The following is a description of a gene set: Human Gene Set: GAVISH_3CA_METAPROGRAM_ENDOTHELIAL_ENDO_5 studied in species Homo sapiens Genes upregulated in subsets of cells of a given type within various tumors In this study, an extensive analysis was conducted to define meta-programs (MPs) capturing intra-tumor heterogeneity across a spectrum of tumor types. The approach utilized non-negative matrix factorization (NMF) to analyze each cell type separately within individual tumor samples. This involved the analysis of malignant cells, macrophages, fibroblasts, endothelial cells, epithelial cells, T-cells, and B-cells. NMF was executed with varying parameter values (K=4, 5, 6, 7, 8, 9), thereby generating 39 programs for each cell type per sample. Each NMF program was summarized by the top genes based on NMF coefficients.\nRobust MPs were then delineated for each cell type using a set of stringent criteria, including recurrence within the same tumor, similarity to programs in other tumors, and non-redundancy within a tumor. Subsequently, these robust NMF programs were clustered (per cell type) based on Jaccard similarity, leading to the identification of MPs associated with each cell type.\nTo enhance the quality of the MPs, a refinement steps were undertaken, involving the removal of MPs suspected of reflecting low-quality data (with an overrepresentation of ribosomal proteins or mitochondrial-encoded genes), single-study inclusion, or similarity to miss-annotated cell types. from publication Gavish A, Tyler M, Greenwald AC, Hoefflin R, Simkin D, Tschernichovsky R, Galili Darnell N, Somech E, Barbolin C, Antman T, Kovarsky D, Barrett T, Gonzalez Castro LN, Halder D, Chanoch-Myers R, Laffy J, Mints M, Wider A, Tal R, Spitzer A, Hara T, Raitses-Gurevich M, Stossel C, Golan T, Tirosh A, Suvà ML, Puram SV, Tirosh I (PMID 37258682), and this is the list of marker genes: RGCC, APOD, TP53I11 (tumor protein p53 inducible protein 11), PDGFB, MARCKS, LAMA4, TNFRSF4, ADM, GPIHBP1, IGF2, PCDH12, GMFG, NID2, LY6H, LXN, EFCAB14, CLDN5, MMP2, RND3, JUP, CHST1, COL4A1, HOMER3, SMAD1, WFS1, IL32, MGLL, TSPAN15, SMTN, SLC38A1, CXCR4, ESM1, SLC4A7, LOX (lysyl oxidase), CYTL1, COTL1, FSCN1, EIF4EBP1, TNFAIP8L1, RGS3, FABP5 (fatty acid binding protein 5), CTHRC1, GYPC, COL12A1, DEPP1, PXDN, LGALS1, CHST15, MCAM, PGF